Given this list of marker genes Cyp27b1, App, Lgi1, Eif1a, Nudcd3, Tnfsf15, Gtdc1, Haus7, Cyp4a31, Fam114a1, Mfsd4a, Ppfia2, Prdx6, Klhl24, Slc34a1, Ppm1b, Phactr1 (phosphatase and actin regulator 1), Nckap1, Nsd3, Stk40, Vamp2, Rbm25, Acnat1, Wdr47, Megf10, Arhgef15, Fos, Vstm2l, Slitrk4 (NCBI Gene Id 245446), Taf7l2, Nkain2, Cfap43, Celf3, Phka1, Klhdc10, Snap47, Afap1l1, Iqsec2, Ccnyl1, Fkbp1b, Clec2h, Tmem267, here is a description of the gene set: studied in species Mus musculus Genes predicted to be targets of miRBase v22 microRNA mmu_miR_465d_3p in miRDB v6.0 with MirTarget v4 prediction scores > 80 (high confidence targets). Mouse Gene Set: MIR_465D_3P from publication Chen Y, Wang X (PMID 31504780)